Given this list of marker genes FOXL1, FHIP2A, ARL6, TNPO1, ZNF549, RNF149, SORCS2, DHFR, INSR, MB21D2, MYDGF, ELOVL2, SLC7A14, WAPL, FBXO31, STYK1, SH3GLB1, MAP4K3, SDCBP, DDI2, RBM47, TMF1, NOSIP, GCNT2, CELF4, INPP5A, PALLD, UBN1, EPPIN-WFDC6, TFAP4, ORC4, FBXO36, ANKS3, CUL1, CCDC59, ALS2, PRH2, GMEB2, PHTF2, PHF2, EXT2, VASH2, DCUN1D3, ZNF12, YWHAZ, DENND6A, TAS2R20, SLC30A1, C8orf44-SGK3, PDZD8, TYW5, SPAG1, ATP10A, LSM14A, ELK4, IQCK, EPHA6, OPA1, MBNL1, BAZ1B, NOTCH2NLA, MRPL19, LPGAT1, HTR1B, CCNJ, MEX3D, PIK3CB, TSTD1, PDE10A, SPOCK3, SPACA1, TRAM1L1, MIA3, CNGB1, NR4A3, NME9 (NME/NM23 family member 9), NHEJ1, ADAM12, MYRIP, SGK3, ZBTB10 (zinc finger and BTB domain containing 10), DLG2, SRFBP1, PTPN1, KCNJ13, RBM46, HAPLN1, PCNX1, AKAP12, COA7, GCSAM, NUP50, GABRA1, TSPAN2, ANKRD37, ZC3H12C, ITPRID2, FAM118A, PSMF1, C1QTNF3 (NCBI Gene Id 81699), CALHM4, MBNL3, FAM120B, SLC17A6, COMMD10, SOS1, ACYP2, BTC, HADH, IGF1R, PUDP, TENM2, OGFRL1, PPP1R3D, NSD3 (nuclear receptor binding SET domain protein 3), TNFAIP3, NAPEPLD, TLE4, RORA (NCBI Gene Id 6095), CCDC126, NCAM2, FLRT3, PAX5, KIFC3, TENT2, RBM12, FZD8, ZNF708, NEK2, PMS2, ZNF501, ERICH1, GDAP2, CHP1, SLCO4C1, AEBP2, CEP120, H6PD (NCBI Gene Id 9563), PFKFB2, TOMM5, SPX, GATA6, PIK3C2A, here is a description of the gene set: studied in species Homo sapiens from publication Chen Y, Wang X (PMID 31504780) Human Gene Set: MIR2116_5P Genes predicted to be targets of miRBase v22 microRNA hsa-miR-2116-5p in miRDB v6.0 with MirTarget v4 prediction scores > 80 (high confidence targets).